Given this list of marker genes Tkfc, Oas3, Ddx60, Ankrd17, Riok3, Usp17le, C1qbp, Dhx58, Ifih1, here is a description of the gene set: The series of molecular signals initiated by the binding of dsRNA from another organism to the cytoplasmic pattern recognition receptor (PRR) MDA-5 (also known as IFIH1). MDA-5 detects RNA synthesized during viral replication or shed by non-viral pathogens, and triggers a signaling pathway to protect the host against infection, for example by inducing the expression of cytokines. studied in species Mus musculus Mouse Gene Set: GOBP_MDA_5_SIGNALING_PATHWAY